Given this list of marker genes MCUB, SPG7, VDAC1, AFG3L2, PSEN2, UCP2, here is a description of the gene set: studied in species Homo sapiens Human Gene Set: GOBP_REGULATION_OF_CALCIUM_IMPORT_INTO_THE_MITOCHONDRION Any process that modulates the frequency, rate or extent of calcium import into the mitochondrion.